Given this list of marker genes CCBE1, ROBO1, VEGFA, TNXB, ADAMTS3, JCAD, GREM1, ITGB1, PROX1, ADGRG1, VTN, ITGB3, ITGA5, SMOC2, MIR21, here is a description of the gene set: Human Gene Set: GOBP_POSITIVE_REGULATION_OF_VASCULAR_ENDOTHELIAL_GROWTH_FACTOR_SIGNALING_PATHWAY species: Homo sapiens Any process that activates or increases the frequency, rate or extent of vascular endothelial growth factor signaling pathway.